Given this list of marker genes FBN1, TAF4, NSD1, DLG4, APC2, TGFB3, TRAPPC2, here is a description of the gene set: Increased arm span species: Homo sapiens Human Gene Set: HP_INCREASED_ARM_SPAN Increased length of the arm span (length from one end of an individual's arms measured at the fingertips to the other when raised parallel to the ground at shoulder height at a one-hundred eighty degree angle).